The following is a description of a gene set: Commissural axons project to the floor plate, attracted by the interaction of their DCC receptors with Netrin-1 (NTN1) produced by floor plate cells and radial glia. Once an axon enters the floor plate, it must be efficiently expelled on the contralateral side. A switch from attraction to repulsion allows commissural axons to enter and then leave the CNS midline. Based on studies in Xenopus neurons and by yeast two hybrid screens, it is observed that the attractive response of axons to netrins is silenced by activation of ROBO. SLIT bound ROBO binds to DCC, preventing it from transducing an attractive response to netrin. The sensitivity of axons to the repulsive action of SLIT does not only depend on repulsive SLIT receptors (ROBO1 and ROBO2), but is also influenced by expression of ROBO3, a SLIT receptor that suppresses the activity of ROBO1 and ROBO2. Upon crossing the midline, commissural axons downregulate expression of ROBO3 and increase expression of ROBO1/ROBO2. Two transcript variants of ROBO3, ROBO3.1 and ROBO3.2 are considered to play different roles in midline crossing. ROBO3.1 is expressed in the pre-crossing and crossing commissural axons, while ROBO3.2, generated by alternative splicing, is expressed after midline crossing and thought to block midline re-crossing. In addition to SLITs, a secreted ligand NELL2 also acts as an axonal guidance cue that, by acting through ROBO3 receptors, helps to steer commissural axons to the midline. Both ROBO3.1 and ROBO3.2 can bind to a secreted ligand NELL2. Pre-crossing commissural axons, which express ROBO3.1, are repelled by NELL2. Post-crossing axons, which express ROBO3.2 are not repelled by NELL2.. Reactome Pathway: Regulation of commissural axon pathfinding by SLIT and ROBO part of: Signaling by ROBO receptors species: Homo sapiens, and this is the list of marker genes: SLIT2, DCC, ROBO2, ROBO1, NELL2, SRC, ROBO3, NTN1, SLIT1, SLIT3